Given this list of marker genes Awat1, Far2, Awat2, here is a description of the gene set: Reactome Pathway: Wax and plasmalogen biosynthesis electronically inferred by orthology from the curated human pathway part of: Metabolism of lipids This event has been computationally inferred from an event that has been demonstrated in another species.<p>The inference is based on the homology mapping from PANTHER. Briefly, reactions for which all involved PhysicalEntities (in input, output and catalyst) have a mapped orthologue/paralogue (for complexes at least 75% of components must have a mapping) are inferred to the other species. studied in species Mus musculus